The following is a description of a gene set: Human Gene Set: HP_PRIMARY_GONADAL_INSUFFICIENCY Primary gonadal insufficiency studied in species Homo sapiens, and this is the list of marker genes: MAP3K1, SOX9, EIF2B1, NSMCE2, WFS1, WT1, WWOX, GATA4, XRCC4, CYP17A1, NR0B1, CYB5A, ZFPM2, SRY, NR5A1, VAMP7, DHX37